Given this list of marker genes Per3, Lgals1, Fabp2, Lepr, Rgs2, Enc1, Acot4, Tmem181a, Rab30, Galk1, Tpx2, Scd2, Me1, Map4k4, Gsta4, Cyp2b13, Slc41a3, Crat, Cela3b, Tmtc2, Rgs16, Adamts5, Gstm2, Cyp7a1, Cyp2b9, Lpl, Aldh3a2, Cdkn1c, Igf2bp3, Acot1, Ccna2 (NCBI Gene Id 99481), Slc51b, Adora1, Acot3, Ccl2, Tnfrsf19, Fabp4, Racgap1, Nqo1, Mgst3, Rab34, Slpi (NCBI Gene Id 20568), Stmn1, Hmmr, Cxcl1, Psat1, Kif2c, Sparcl1, Serpinb1a, Slc20a1, Ect2, Ucp2, Dbp, Thbs1, Afp, Aurkb (NCBI Gene Id 20877), Cdc20, Abcc4, Sorbs1, Fmo3, Gas2l3, Ptgfr, Pparg, Pctp, Ccnb1, Impa2, Maoa, Tmem116, Cyp2c39 (NCBI Gene Id 13098), Adra2a, Ube2c, Cdca8, Por, Trpm4, Mcm2, Mgst2, Elovl6, Gprc5b, Cyp2a5, Tmem98, Esco2, Ntf3, Slc22a5, Sdcbp2, Acot2, Txnip, Mtnr1a, Arhgap18, Abcb1a, Slc25a4 (NCBI Gene Id 11739), P2ry14, Gadd45b, Akr1b7, Bub1, Mad2l1, Gsta1, Asns, Rab27a, Abcc3, Sult1e1, Nln, Fgfrl1, Cbr3, Ly6k, Akr1c19, Gstm3 (NCBI Gene Id 99537), Mmp12, Cyp4a14, Atp6v0d2, Igf2r, Anxa2, Cbr1, Kif11, Akap12, Fgf9, Wee1, Cyp4a10, Gsta2, Anln, Pcdh20, Mmd, Npnt, Rragd, Tm4sf4, Mogat1, Slc7a4, Septin6, Cdc42ep5, Htra3, Olig1, Pdk4, Adamts4, Slco1a4, Serpine1, Gstt2, Tnfrsf12a, Pygb, Kif20a, Ccnb2, Ly6d, Pltp, Abcd2, Nek2, here is a description of the gene set: from publication Servitja JM, Pignatelli M, Maestro MA, Cardalda C, Boj SF, Lozano J, Blanco E, Lafuente A, McCarthy MI, Sumoy L, Guigó R, Ferrer J (PMID 19289501) Genes up-regulated in liver tissue upon knockout of HNF1A. Heterozygous HNF1A mutations cause pancreatic-islet beta-cell dysfunction and monogenic diabetes (MODY3). Hnf1alpha is known to regulate numerous hepatic genes, yet knowledge of its function in pancreatic islets is more limited. We now show that Hnf1a deficiency in mice leads to highly tissue-specific changes in the expression of genes involved in key functions of both islets and liver. To gain insights into the mechanisms of tissue-specific Hnf1alpha regulation, we integrated expression studies of Hnf1a-deficient mice with identification of direct Hnf1alpha targets. We demonstrate that Hnf1alpha can bind in a tissue-selective manner to genes that are expressed only in liver or islets. We also show that Hnf1alpha is essential only for the transcription of a minor fraction of its direct-target genes. Even among genes that were expressed in both liver and islets, the subset of targets showing functional dependence on Hnf1alpha was highly tissue specific. This was partly explained by the compensatory occupancy by the paralog Hnf1beta at selected genes in Hnf1a-deficient liver. In keeping with these findings, the biological consequences of Hnf1a deficiency were markedly different in islets and liver. Notably, Hnf1a deficiency led to impaired large-T-antigen-induced growth and oncogenesis in beta cells yet enhanced proliferation in hepatocytes. Collectively, these findings show that Hnf1alpha governs broad, highly tissue-specific genetic programs in pancreatic islets and liver and reveal key consequences of Hnf1a deficiency relevant to the pathophysiology of monogenic diabetes. Mouse Gene Set: SERVITJA_LIVER_HNF1A_TARGETS_UP studied in species Mus musculus